Given this list of marker genes LYG2, SPACA5, SPACA3, SPACA5B, LALBA, LYZL4, LYG1, LYZL2, LYZ, LYZL1, LYZL6, here is a description of the gene set: Catalysis of the hydrolysis of the beta-(1->4) linkages between N-acetylmuramic acid and N-acetyl-D-glucosamine residues in a peptidoglycan. species: Homo sapiens Human Gene Set: GOMF_LYSOZYME_ACTIVITY